Given this list of marker genes STARD10, GIMAP7, MPHOSPH6 (M-phase phosphoprotein 6), S100A11, CHPT1, NUDT4, S100A13, RAP2A, PGLYRP1, CCR2, GNPTAB, CLIC4, NFIL3, CHSY1, SERPINB9, SMPDL3B, LPIN2, GABARAPL1, ESM1, NPTN, AIF1, ZEB2, DSTN, BAG1, SNX10, KLRC1, CASP4 (caspase 4), H2BC4, PHLDA1, PPM1J, ATXN1, NDUFA1, PRR13, MYL6, LAMC1, CRIP1, AP1S2 (NCBI Gene Id 8905), EFHD2, GEM, PHF11, CARHSP1, RBM47, BEX3, RUNX2, RGS1, NR4A1, RILPL2, SAP30, GNG2, PRKAR2A (protein kinase cAMP-dependent type II regulatory subunit alpha), GZMA, IL18R1, YBX3, SYPL1, MED7, CHST11, CYSLTR2, SLAMF7, TMEM163, ATF6, LAIR1, PLEK, LEPROT, ANXA1, CCL3, S100A6, GALNT3, GZMB, ARHGAP18 (Rho GTPase activating protein 18), CXCR3, ITGAX, ANXA4, NFKBIB, INSL6, HTATIP2, LGALS1, GSAP (gamma-secretase activating protein), LXN, PCGF2, NCALD, KLRK1, MYADM, CALM2, CWC15, DAPK2, MARCKSL1, ALCAM, ACOT7, PIK3AP1, IFNG, PTMS, RPA2, FGL2, PRDM1, SWAP70, CKS2, SLA, CCDC50, RORA, PRF1, CCL4, DUSP5, NKG7, SYTL2, IFNGR1, CRYBG1, IL18RAP, COBLL1, TBX21, CALM3, ARF6, PRDX4, C6orf89, PTPRJ, NIBAN1, SLC25A24, CASP1, GGH, ARHGAP10, ZDHHC2, AP3S1, LILRB4, PRKX, ATP2B4, OSBPL3, GZMK, S100A10, ITGB1, MYO1F, APOBEC2, ANAPC13, CD80, TCEAL9, NLN, GAPDH, RAP1GAP2, ENTPD1, SLC4A7, S100A4, ASRGL1 (NCBI Gene Id 80150), GMDS, DDX28, HOPX, GNG10, PERP, CD48, COX17, PACSIN2, PLSCR1, KLRC2, ARSB (arylsulfatase B), CAPN2, ECH1, S100A8, NDUFS6, SPTY2D1, PMAIP1, TIGIT, KLRG1, CD63, NRP1, DGKH, H1-0, CCL5, TXNDC17, CD44, DOCK5, S100A9, LY6S, SRGN, RNF216, TTC39C, REEP5, SUB1, BHLHE40, ERRFI1, ID2, AHNAK, ATOX1, here is a description of the gene set: from publication Ng SY, Yoshida T, Zhang J, Georgopoulos K (PMID 19345118) Genes down-regulated in IKZF1 knockout: lymphoid-primed multipotent progenitors versus megakaryo-erythrocyte progenitors. Regulation of lineage potential and transcriptional priming by Ikaros. New insight is provided into a bivalent regulation of lineage priming in the HSC and its lympho-myeloid restricted progeny the LMPP by the lymphoid lineage-determining factor Ikaros Whereas Ikaros is responsible for the activation of a cascade of lymphoid expression programs and for the establishment of lymphoid potential from the HSC to the LMPP it is also responsible for the repression of stem cell and erythroid genetic programs that are incompatible with further lineage restrictions emanating from the LMPP studied in species Homo sapiens Human Gene Set: GSE15330_LYMPHOID_MULTIPOTENT_VS_MEGAKARYOCYTE_ERYTHROID_PROGENITOR_IKAROS_KO_DN